The following is a description of a gene set: Mouse Gene Set: GOMF_LIGAND_GATED_CHANNEL_ACTIVITY studied in species Mus musculus Enables the transmembrane transfer of a solute by a channel that opens when a specific ligand has been bound by the channel complex or one of its constituent parts., and this is the list of marker genes: Glra3, Cngb1, Cngb3, Gabra3, Grin2d, Cftr, Kcnj2, Kcne2, Best2, Ryr2, Chrnd, Chrnb3, Hcn2, Gabrg1, Aqp1, Rasa3, Glra4, Clca4a, Trpc3, Grik5, Kcnj11, P2rx2, Hcn3, Best3, Asic2, Grid2, Kcnj10, Gabrq, Kcnmb3, Glrb, Kcnma1, Asic4, Gabrp, Grin2c, Nmur2, Kcnj13, Gabrr1, Chrne, Grin2a, Gabrb2, Mcoln3, Gria2, Cnga3, Pkd2l1, Catsper4, Kcnu1, Gabrr2, Kcnj15, Ano10 (NCBI Gene Id 102566), Kcnmb1, Scnn1a, Trpm8, Itpr3, Kcnh6, Ano1, Itpr1, Gabrb1 (NCBI Gene Id 320243), Bnip1, Pkd1l3, Kcnj6, Clca3a2, Chrnb1 (NCBI Gene Id 11443), Gabrd, Gria3, Kcnj8, Glra2, Ano2, Tmem63b, Clca1, Gabrg3, Gria1, Kcnn4, Chrna1, Kcnj5, Clca3b, P2rx7, Kcnk18, Grid1, Chrna3, Tpcn2, Chrm5, Gabrb3 (GABRB3, gamma-aminobutyric acid type A receptor subunit beta 3), Best1, Trpm4, Grin3b, Clca4b, Mcoln2, Kcnmb4, Tmem63c, Asic3, Cnga4, Trpm5, Hcn4, Kcnt1, Chrna10, Pex5l, Asic5, Ryr1, Ano4, P2rx3, Ano9, Chrna9, Trpv1, P2rx5, Kcnmb2 (NCBI Gene Id 73119), Kcnj3, Kcnj4, Asic1, Scnn1g, Kcnj12, Kcnn2, Chrng, Ano5, Kcnk2, Gabra5, Chrna4, Slc1a5, Pkd2, Catsper1, P2rx4, Grik2, Atp5mc1, Catsper2, Calhm1, Kcnt2, Chrna7, Chrna2, Clca2, Gabra1 (gamma-aminobutyric acid type A receptor subunit alpha 1), Ano6, Chrnb2, Htr3b, Grik1, Ano3, Kcnj9, Chrna6, Cav1, Kcnn3, Kcnj16, Grik4, Atp5mc2, Grin1, P2rx1, Chrna5, Aqp6, Gabra2, Grin3a, Gabrg2, Tmem63a, Cnga1, Ano8, Ccdc51, Kcnn1, Kcnk1, Trpm2 (transient receptor potential cation channel, subfamily M, member 2), Kcnj1, Mcoln1, Ttyh2, Grik3, Slc17a7, Tmem38a, Itpr2, Kcnj14, P2rx6, Grin2b (NCBI Gene Id 14812), Ryr3, Scnn1b, Slc1a7, Trpa1, Clca3a1, Cnga2, Anxa6, Chrnb4, Kcnh7, Htr3a (5-hydroxytryptamine (serotonin) receptor 3A), Ano7, Pacc1, Ttyh1, Ttyh3, Glra1, Atp5mc3, Gabra6, Gria4, Gabra4, Kcnh2, Gabre, Kcnh3, Tpcn1, Hcn1